Given this list of marker genes INO80D, CADM1, PSME4, TRPS1, NECAP1, HECTD1, SCUBE3, TBL1XR1, MAGI3, MMP2, PLPPR1, BPTF, ALB, ABL2, PIK3R4, LRIT3, DLC1, WDR48, PHF6, ADD2, COL5A3, TCEAL8, SMDT1, PABIR2, SUSD4, TET1, ITGB8, MAPK1, C3orf38, EXOC2, SELL, KAT6A, TMEM67, MSI2, FNDC5, SPRED3, SENP7, C2orf88, RFLNB, ZNF746, CACNA1E, CDK17, IGFBP5, WDFY3, CAPZA1, C6orf62, HK2, UACA, CACHD1, FRS2, TBC1D12, TYSND1 (NCBI Gene Id 219743), CACNA2D3, ACSF3, BCL2 (NCBI Gene Id 596), ITM2B, DERL2, MYO6, AHCYL1, ASH1L, PNKD, ANXA3, PACRG, FBXO46, PURA, FTSJ1 (FtsJ RNA 2'-O-methyltransferase 1), OSER1, SLC25A53, PGK1, BBS9, CNTD1, ABHD17B (abhydrolase domain containing 17B, depalmitoylase), MOGS, GLI3, FSCN1, STOX2, SLC15A4, AIG1, ZKSCAN7, TCEAL9, MRTFB, CLEC16A, TMEM178B, KIF3B, PDIA6, THRB, BLTP3B, WIPF2, COL21A1, AMIGO3, FRMPD2, CD300LF, here is a description of the gene set: Genes predicted to be targets of miRBase v22 microRNA hsa-miR-4708-5p in miRDB v6.0 with MirTarget v4 prediction scores > 80 (high confidence targets). from publication Chen Y, Wang X (PMID 31504780) Human Gene Set: MIR4708_5P studied in species Homo sapiens